Given this list of marker genes Mpo, Atp6v1b2, Rac2, Ncf1, Atp6v0e, Slc11a1, Atp6v0c, Cybb, Atp6v0e2, Nos3, Atp6v0a4, Atp6v1c1, Ncf2, Atp6v1h, Atp6v1g1, Atp6v0a1, Nos2, Atp6v1e1, Tcirg1, Atp6v1c2, Hvcn1, Atp6v1e2, Atp6v0d1, Atp6v1a, Atp6v1g3, Ncf4, Atp6v1g2, Atp6v1d, Nos1, Atp6v0d2, Atp6v1b1, Lpo, Cyba, Atp6v1f (ATPase, H+ transporting, lysosomal V1 subunit F), Atp6v0b, Atp6v0a2, here is a description of the gene set: species: Mus musculus ROS and RNS production in phagocytes Mouse Gene Set: REACTOME_ROS_AND_RNS_PRODUCTION_IN_PHAGOCYTES